The following is a description of a gene set: species: Homo sapiens Human Gene Set: GOBP_REGULATION_OF_FERTILIZATION Any process that modulates the rate, frequency or extent of fertilization. Fertilization is the union of gametes of opposite sexes during the process of sexual reproduction to form a zygote. It involves the fusion of the gametic nuclei (karyogamy) and cytoplasm (plasmogamy)., and this is the list of marker genes: ZP2, PRSS37, WEE2, ZP4, PLAT, TPST2 (tyrosylprotein sulfotransferase 2), PLCB1, ZP1, PRDM9, RNASE10, NLRP5, FAM170B, CCDC87, ASTL, LHFPL2, INTS13, MYH9, CFAP69